The following is a description of a gene set: Mouse Gene Set: GOBP_RESPONSE_TO_MACROPHAGE_COLONY_STIMULATING_FACTOR Any process that results in a change in state or activity of a cell or an organism (in terms of movement, secretion, enzyme production, gene expression, etc.) as a result of a macrophage colony-stimulating factor stimulus. species: Mus musculus, and this is the list of marker genes: Ddr1, Epha5, Flt1, Epha10, Fgfr4, Egfr, Epha4, Erbb2, Pdgfra, Axl, Ltk, Fgfr2, Trem2, Mst1r, Epha1, Ror2, Ephb2, Ntrk3, Ptpn2 (NCBI Gene Id 19255), Tek, Epha2, Tnf, Alpl, Fgfr1, Erbb4, Ccl2, Tlr4, Mertk, Musk, Ephb3, Kdr, Ntrk2, Ddr2, Fer, Insrr, Pdgfrb, Ros1, Tlr2, Fgfr3, Flt4, Tie1, Epha7, Igf1r, Ephb4, Stap1, Dcstamp, Csf1r (colony stimulating factor 1 receptor), Pde1b, Alk, Ntrk1, Csf1, Pde2a, Epha6, Tyro3, Ret, Dok1, Epha8, Epha3, Flt3, Insr, Met, Kit, Ephb1